The following is a description of a gene set: Apoptotic cells show dramatic rearrangements of tight junctions, adherens junctions, and desmosomes. Desmosome-specific members of the cadherin superfamily of cell adhesion molecules including desmoglein-3, plakophilin-1 and desmoplakin are cleaved by caspases after onset of apoptosis. Cleavage results in the disruption of the desmosome structure and thus contributes to cell rounding and disintegration of the intermediate filament system. species: Homo sapiens part of: Apoptotic cleavage of cellular proteins Reactome Pathway: Apoptotic cleavage of cell adhesion  proteins, and this is the list of marker genes: DSP, CDH1, DSG3, CASP3, PKP1, DSG2, CTNNB1, DSG1, TJP1, OCLN (occludin), TJP2